The following is a description of a gene set: studied in species Mus musculus Mouse Gene Set: GOBP_MESENCHYME_MIGRATION The process in which the population of cells that make up a mesenchyme undergo directed movement., and this is the list of marker genes: Foxf1, Actg2, Acta1, Actc1, Acta2